Given this list of marker genes RSPO2, THBS3, CXCL13, PRG2, EVA1C, SAA1, RCC1, SULT2A1, SAMTOR, LANCL1, LPA, SOD3, GSTM1, PTPRF, HLCS, GSTP1, BSPH1, ADAMTS8, ECM2, METTL3, SULT1A1, PRMT1, RSPO1, COL28A1, PAFAH1B1, CRISPLD2, DPYSL3, SPOUT1, H1-1, ADAMTS15, ECI2, CCL15, FGFBP3, AMBP, PPIA, CTSG, MSTN, RPL22, TFB1M, ADAMTSL5 (NCBI Gene Id 339366), ANGPTL3, FBN1, PCOLCE, NRTN, COL5A1, BMP4, FN1, BMP7, GFRA2, APLP1, CLEC3B, PLA2G2D, ENPP1, CCN1, SELL, PCIF1, TGFBR3, SLIT2, PTPRS, TPK1 (thiamin pyrophosphokinase 1), GSTM2, LIPG, RTN4R, N6AMT1, MMACHC, TWSG1, ADA2, CCL23, FGF2 (NCBI Gene Id 2247), AOC1, ADAMTS1, APP, HACL1, LIPC, NAA80, KNG1, FGFR1, GPNMB, P2RX1, TNXB, PTGES2, FGF9 (NCBI Gene Id 2254), PC, VEGFA, LGR6, CXCL11, COL23A1, SULT1A4, FSTL1, DMBT1, LIPI, CD34, PRMT8, PTPRC, SCP2, HRG, CCN6, SFRP1, SETD6, SLIT1, GSTM3, ADGRG1, GNMT, THBS1, APOB, MGST2, SERPIND1, ACACB, LAMC2, PF4V1, NRP1, ACOT7, CEL, ADAMTS5, FST, AAMP, NELL1, APOE, ACBD3, SOAT2, PCCA, ELANE, HS3ST5, SERPINC1, VEGFB, MPIG6B, CXCL6, CCN2, HPSE2, PNPLA3, HSD17B12, CXCL8, THBS4, PRELP, HMGCR, GAL3ST4, F11, SLIT3, UST, AZU1 (NCBI Gene Id 566), RSPO4, THBS2, ILVBL, FURIN, ZCCHC4, LXN, TMEM184A, OGDHL, CHST12, GAL3ST3, COL25A1, NDNF, HDGF, FGF7, APOA5, PTCH1, TNFRSF11B, METTL14, GLRA1, GNS, ACBD4, DBI, OGDH, LPL, ZNF207, SEMA5A, TKTL2, TKT, MDK, RPL29 (NCBI Gene Id 6159), ACBD7, SULT1C3, GSS, LIPH, IMPG1, FGF4 (NCBI Gene Id 2249), TPMT, PTN, POSTN, PRSS57, LTBP2, NRP2 (NCBI Gene Id 8828), FGF20, CXCL10, ANOS1, DHTKD1, PGF, ADGRE2, CCN3 (NCBI Gene Id 4856), TMEM120A, ACADVL, ACBD5, LRPAP1, SUV39H2, RYR2, COMP, IMPG2, VTN, FBLN7, PDCD5, RSPO3, FGF14, TSR3, FGFRL1, COL13A1, TKTL1, PCOLCE2, CBS, MPO, ACAT1, CHST15, SOST, PANK3, GCDH, ALK, METTL17 (methyltransferase like 17), ELSPBP1, APLP2, SERPINE2, FGF1, LTF (lactotransferrin), DBT, REG4, CCDC80, ZNF146, SMOC1, CCN4, ADAMTS3, PF4, LRP1, COL5A3, FGFBP1, COLQ, CCN5, MOCS1, ACBD6, KMT5B, PANK1, GSTM4 (glutathione S-transferase mu 4), PCSK6, AGRN, KMT5C, NELL2, NAV2, FGFR4, ENSG00000274276, SOAT1 (sterol O-acyltransferase 1), DEFB106B, HBEGF, TAF1 (NCBI Gene Id 6872), SMAD4, METTL5, CCL7, EFEMP2, APOH, SERPINA5, CCL8, FTSJ1, GREM2, F2, SULT1A3, FGF10, CFH, TENM1, FGF12, SMOC2, ANG, MCCC1, DEFB106A, FGFR2, COL11A1, SELP, ITGA2, RTN4RL1, PTGES, SERPINA10, here is a description of the gene set: species: Homo sapiens Human Gene Set: GOMF_SULFUR_COMPOUND_BINDING Binding to a sulfur compound.